The following is a description of a gene set: Development of a photoreceptor, a sensory cell in the eye that reacts to the presence of light. They usually contain a pigment that undergoes a chemical change when light is absorbed, thus stimulating a nerve. Mouse Gene Set: GOBP_EYE_PHOTORECEPTOR_CELL_DEVELOPMENT studied in species Mus musculus, and this is the list of marker genes: Bhlhe23, Rorb (RAR-related orphan receptor beta), Ush1c, Pde6c, Cabp4, Mir124a-2, Ahi1, Hcn1, Gabrr2, Cep290, Mir183, Nrl, Rpgrip1, Miat, Mfrp, Samd7, Pax6, Rp1, Mir96, Ntrk2, Rpgr, Mir124a-1, Vegfa (NCBI Gene Id 22339), Prdm1, Trpm1, Naglu, Samd11 (sterile alpha motif domain containing 11), Dzank1, Cnga3 (NCBI Gene Id 12790), Tulp1, Th, Fscn2, Dio3, Bbs4, Cfh, Rdh13, Crb1, Rpgrip1l, Alms1, Poc5, Nr2e3, Gnat2, Mir182, Prkci, Crb2, Pdgfb, Gngt1 (guanine nucleotide binding protein (G protein), gamma transducing activity polypeptide 1), Thy1, Gnat1, Thrb, Olfm3